The following is a description of a gene set: Secreted protein acidic and rich in cysteine (SPARC) is an extracellular glycoprotein expressed in several solid cancers, including malignant gliomas, upon adoption of metastatic or invasive behaviors. SPARC expression in glioma cells promotes invasion and survival under stress, the latter process dependent on SPARC activation of AKT. Here we demonstrate that downregulation of SPARC expression with short interfering RNA (siRNA) in glioma cells decreased tumor cell survival and invasion. SPARC siRNA reduced the activating phosphorylation of AKT and two cytoplasmic kinases, focal adhesion kinase (FAK) and integrin-linked kinase (ILK). We determined the contributions of FAK and ILK to SPARC effects using SPARC protein and cell lines engineered to overexpress SPARC. SPARC activated FAK and ILK in glioma cells previously characterized as responsive to SPARC. Downregulation of either FAK or ILK expression inhibited SPARC-mediated AKT phosphorylation, and targeting both FAK and ILK attenuated AKT activation more potently than targeting either FAK or ILK alone. Decreased SPARC-mediated AKT activation correlated with a reduction in SPARC-dependent invasion and survival upon the downregulation of FAK and/or ILK expression. These data further demonstrate the role of SPARC in glioma tumor progression through the activation of intracellular kinases that may provide novel therapeutic targets for advanced cancers. Human Gene Set: SHI_SPARC_TARGETS_DN from publication Shi Q, Bao S, Song L, Wu Q, Bigner DD, Hjelmeland AB, Rich JN (PMID 17213807) Genes down-regulated in glioma cell lines after knockdown of SPARC by RNAi. studied in species Homo sapiens, and this is the list of marker genes: ITGB2 (integrin subunit beta 2), SPARC, HILPDA, MAP3K8, PPP5C, TP53TG3, AHR, SEMA3B, SPARCL1, KIT, RAB40B, MAPK15, BBC3